Given this list of marker genes CCDC110 (NCBI Gene Id 256309), RAD17 (RAD17 checkpoint clamp loader component), SLC12A8, FAM3C, SEC62, GLCCI1, ANKRD20A5P, RGCC, AIG1, BRSK1, PTCH1, PRKCA, DKK1, SCAPER, KLHL42, CHST11 (carbohydrate sulfotransferase 11), TNFAIP8, CREB3L2, MOB1B, TMEM170B, ITSN1, ENSG00000279249, SYNGR1, ZNF275, PDZRN4 (NCBI Gene Id 29951), MTDH, APH1B, ALDH2, TMEM52B, ANKRD36BP2, AMIGO2, RAPGEF2, ENAH, TRANK1, ATXN1-AS1, SLC22A15, GPLD1, NRG3 (NCBI Gene Id 219505), ESRRG, STRBP (NCBI Gene Id 55342), DOCK9, MOXD1, STXBP6, CAMK1D, ARMC2, here is a description of the gene set: studied in species Homo sapiens from publication Zhan F, Huang Y, Colla S, Stewart JP, Hanamura I, Gupta S, Epstein J, Yaccoby S, Sawyer J, Burington B, Anaissie E, Hollmig K, Pineda-Roman M, Tricot G, van Rhee F, Walker R, Zangari M, Crowley J, Barlogie B, Shaughnessy JD Jr (PMID 16728703) Human Gene Set: ZHAN_MULTIPLE_MYELOMA_MF_DN To better define the molecular basis of multiple myeloma (MM), we performed unsupervised hierarchic clustering of mRNA expression profiles in CD138-enriched plasma cells from 414 newly diagnosed patients who went on to receive high-dose therapy and tandem stem cell transplants. Seven disease subtypes were validated that were strongly influenced by known genetic lesions, such as c-MAF- and MAFB-, CCND1- and CCND3-, and MMSET-activating translocations and hyperdiploidy. Indicative of the deregulation of common pathways by gene orthologs, common gene signatures were observed in cases with c-MAF and MAFB activation and CCND1 and CCND3 activation, the latter consisting of 2 subgroups, one characterized by expression of the early B-cell markers CD20 and PAX5. A low incidence of focal bone disease distinguished one and increased expression of proliferation-associated genes of another novel subgroup. Comprising varying fractions of each of the other 6 subgroups, the proliferation subgroup dominated at relapse, suggesting that this signature is linked to disease progression. Proliferation and MMSET-spike groups were characterized by significant overexpression of genes mapping to chromosome 1q, and both exhibited a poor prognosis relative to the other groups. A subset of cases with a predominating myeloid gene expression signature, excluded from the profiling analyses, had more favorable baseline characteristics and superior prognosis to those lacking this signature. Top 50 down-regulated genes in cluster MF of multiple myeloma samples with characteristic expression spike of MAF family transcription factors.